Given this list of marker genes ELOVL3, ALDOA, TRIB3, SLC2A1, GPI, EHHADH, RBP4, GK, ERO1A, PFKP, FGF21, COX7A1, ENO1, GAPDH, NDRG1, CBR1, SCD, KLF15, PGK1, TPI1, HIGD1A, CHCHD10, IGFBP4, PDXP, OLR1, MRAP, EGLN3, KLB, here is a description of the gene set: Peroxisome proliferator-activated receptor gamma (PPARgamma) activity is regulated through association with ligands that include the thiazolidinedione class of antidiabetic drugs, as well as derivatives of polyunsaturated fatty acids. Induction of PPARgamma target gene expression involves ligand-dependent reconfiguration of the ligand-binding domain (LBD), followed by recruitment of specific transcriptional coactivators. In this study, we have identified an amino acid (F372) within helix 7 of the LBD that is required for the response of PPARgamma to endogenous ligands. Additionally, the data show that this amino acid is also required for expression of a novel subset of adipocyte genes (group 2), including fibroblast growth factor 21 (FGF21), and that the FGF21 gene is a direct target of PPARgamma. Expression of the group genes is selectively repressed by the NAD-dependent deacetylase SIRT1 in mature 3T3-L1 adipocytes, since knockdown of SIRT1 through the constitutive expression of a corresponding RNA interference enhances their expression without affecting the expression of classic adipogenic genes, such as adiponectin and FABP4/aP2. It appears that many of the group genes repressed by SIRT1 in mature adipocytes correspond to the same set of genes that are selectively activated by treatment of fat cells with the PPARgamma ligand, troglitazone. These data support a role for helix 7 of the LBD of PPARgamma in regulating adipocyte function and suggest that inhibition of SIRT1 in adipocytes induces the same insulin-sensitizing action as PPARgamma ligands. studied in species Mus musculus Human Gene Set: WANG_ADIPOGENIC_GENES_REPRESSED_BY_SIRT1 from publication Wang H, Qiang L, Farmer SR (PMID 17954559) Adipogenic genes (group 2) that are selectively repressed by SIRT1 in mature 3T3-L1 adipocytes.